The following is a description of a gene set: Human Gene Set: GSE32901_TH1_VS_TH17_NEG_CD4_TCELL_UP Genes up-regulated in CD4 T cells: Th1 versus Th17 negative. species: Homo sapiens In this study, we examined differential gene expression in naïve human CD4+ T cells, as well as in effector Th1, Th17-negative and Th17-enriched CD4- T cell subsets. We observed a marked enrichment for increased gene expression in effector CD4+ T cells compared to naive CD4+ among immune-mediated disease oci genes. Within effector T cells, expression of disease-associated genes was increased in Th17-enriched compared to Th17-negative cells. We used microarray to examine the gene expresssion profile and level of human naïve, Th1 and effector T cell subsets. from publication Zhang W, Ferguson J, Ng SM, Hui K, Goh G, Lin A, Esplugues E, Flavell RA, Abraham C, Zhao H, Cho JH (PMID 22715389), and this is the list of marker genes: MED12L, FGFR1, LSMEM2, TGM6, SETD2, VIPAS39, MALT1, RBL1 (RB transcriptional corepressor like 1), SLC6A19, TCF12, PID1, MMRN1, FAT2, H2AC6, NPAS2, GCH1, KCMF1, VEZT, UGCG, KCTD14, UTP4, TUT4, DOCK5, RNPS1, FNBP4, SCN5A, DCAF1 (NCBI Gene Id 9730), INTS6, PTPRO, P2RY1, IGDCC3, ADGRG1, CASP2, SLAMF9, HDDC3, RASGRP4, SPDL1, IRAK3, SRPRA, OSMR, PAN2, CPNE4, CDYL2, GJE1, CAMK1G, MCOLN3, ERO1B (NCBI Gene Id 56605), ATF2, EIF5, ERBIN, BPIFB3, SLC26A9, LARP4, HGD, STAT3 (signal transducer and activator of transcription 3), SUSD2, ZSWIM1, BGLAP, SYCP2L, DR1, PCDH17, MMP21, OC90, PAQR3, SAMHD1, MIR23A, LATS1, URI1, ZFAND3, MTHFD1L (methylenetetrahydrofolate dehydrogenase (NADP+ dependent) 1 like), LRRC59, IPCEF1, KRTAP1-3, SRGN, SLC27A2, PRSS16, TMEM255A, SHOC2, P2RX1, PGGHG, LNPEP, ZFP36, DEFB1, DTX4, PI15, TLE6, MSMO1, GLT8D2, SRPX2, MIR455, TMC3, TMEM39A, SCPEP1, MIR191, PA2G4, MOS, APOM, CSF2RB, SLC25A36, HACD1, SFXN5, EIF2A, GLRX2, TAP1, GTPBP10 (NCBI Gene Id 85865), PIEZO1, PHKB, POLD3, TLN2, MAP3K13, MOSPD3, TIA1, GLCCI1, CSPG5, GPATCH8, NUDT11, SLC29A3, CXCR4, ANKRD17, SCN7A, CD38, MIR128-2, TEX264, IGSF9B, FCHO2, TBL2, CD207, STAU2, RNF38, JAZF1, AOC1